The following is a description of a gene set: studied in species Mus musculus electronically inferred by orthology from the curated human pathway part of: Cytokine Signaling in Immune system This event has been computationally inferred from an event that has been demonstrated in another species.<p>The inference is based on the homology mapping from PANTHER. Briefly, reactions for which all involved PhysicalEntities (in input, output and catalyst) have a mapped orthologue/paralogue (for complexes at least 75% of components must have a mapping) are inferred to the other species. Reactome Pathway: Signaling by Interleukins, and this is the list of marker genes: Cntfr, Sqstm1, H3c11, Il6, Nfkb2, Vamp2, Irs1, Pik3cb (phosphatidylinositol-4,5-bisphosphate 3-kinase catalytic subunit beta), Il15, Il11ra1, Ppp2r5d, Psmd12, H3c13, Shc1, Mapk7, H3c4, Il5ra, Vav1, Il21, Il20, Cntf (NCBI Gene Id 12803), Csf1r, Irak3, Il23r, Gsdmd, Irs2, Hsp90b1, Ager, Rela (NCBI Gene Id 19697), Myd88, Il9, Psmd13, Smarca4, Il24, Peli2, Casp3, Mapk11, Grb2, Ctf1, Tab3, Nfkbib, Il9r, Il27ra, Il1r2, Psmb6, Irak1, Socs1, Il3, Brwd1, Stat5b, Il2rb, Tab2, Il34, Psma5, Il11, Il31, Il20ra, Tyk2, Ifnl2, H3c6, H3c8, P4hb, H3c15, Il18bp, Nkiras1, Psmb7, Il4ra, Dusp7, Il22, Lrrc14, Il36a, Fos, Il23a, Inppl1, Tslp, Fyn, Csf2rb, Psmc3, Psmd7, Il18rap, Il12b, Psmc4, Stx4a, Il10ra, Casp1, Il33, Il18r1, Mapk14 (NCBI Gene Id 26416), Ikbkb, H3c1, Ube2v1, Psmc6, Map2k4, Hmgb1, Crlf1, H3c2, Psmd1, Ube2n, Psma7, Il12a, Psma2, Il4, Ifnlr1, Psma1, Il19, Tec, Dusp6, Il16, Osm, Sdc1, Map3k3, Mapk3, Pik3r2, H3c7, Il2rg, Rps6ka5, Psmc5, Psmb5, Map2k6, Rps27a, Nfkb1, H3c10, Csf2, Il36b, Il10, Sos2, Il1a, S100b, Ppp2r1b, Psma3, Tifa, Il2ra, Il1rl1, Map2k3, Il21r, Psmc2, Ubb, Lck, Casp8, Stat4, Il27 (NCBI Gene Id 246779), Nfkbia, Syk, Psmb4, Ctsg, Jun, Il1r1, H3c3, Il2, Il31ra, Ifnl3, Stx3, Il13ra2, Psma4, Map3k8, Osmr, Stx1a, Clcf1, Stat5a, Mapk9, Psmc1, Il13ra1, Ptpn6, Tab1, Il6ra, Crk, Nlrx1, Psmd6, Mapk8, Vrk3, Lif, Il1f10, Psma6, Cbl, Jak3, Socs3, Yes1 (NCBI Gene Id 22612), Prkaca, Cul1, Il5, Map2k7, Nlrc5, Ebi3